The following is a description of a gene set: species: Homo sapiens Neighborhood of ARAF1 NULL in the MORF expression compendium Human Gene Set: MORF_ARAF1 Neighborhood of ARAF1, and this is the list of marker genes: RXRB, HSF4, ARAF, LYPLA2, CNP, CNOT4, OTUB1, TUBGCP2, PRPH, PLIN3, ACKR2, IKBKG, DRG2, TUB, LMTK2, LUZP1, PML (NCBI Gene Id 5371), RPLP2, ZBED1, HMG20B (NCBI Gene Id 10448), PVT1, TNK2, TPT1, MMP25, CNTN1, LGALS9, PAX8, COPS6, FZR1, RASSF7, EML3, LPAR2, M6PR, CIZ1 (NCBI Gene Id 25792), GRM4 (glutamate metabotropic receptor 4), IGSF9B, ARHGEF1, STK19, GPR161, RABGGTA, AGPAT1, H3-3A, CACTIN, NHERF2, RPS24 (ribosomal protein S24), CNPPD1, ADAM15, PDPK1, PRKCSH, MAN2C1, MVK, SLC9A1, ATXN7L1, NELFB, GPR35 (G protein-coupled receptor 35), GSK3A, ALDH4A1, PTMA, MR1, MTX1, USP11, PCBP3, BTBD2, ARVCF, RAP1GAP2, B4GALT3, LTK, ZFPL1, IGHMBP2, GRK6, SLC12A4, DHRS1, GTF2F1, RABAC1, KAT7, TSPO2, NUDT3, PCGF2 (polycomb group ring finger 2)